The following is a description of a gene set: from publication Chen Y, Wang X (PMID 31504780) Human Gene Set: MIR1193 species: Homo sapiens Genes predicted to be targets of miRBase v22 microRNA hsa-miR-1193 in miRDB v6.0 with MirTarget v4 prediction scores > 80 (high confidence targets)., and this is the list of marker genes: SMG6, HTR4, ARID2, GPLD1, TMEM11, GPM6A, YY1AP1, CMTR2, GSG1L, ITGAV, USP15 (NCBI Gene Id 9958), ORC4, PLEKHB1, SLC1A3, MBD2, TOMM20, ERMAP, TLK2, CHD9, RYR2, CES4A, FAM169BP, PLPPR5, NCK2, SUCLG2 (NCBI Gene Id 8801), TATDN3, NMI, CADM2, IGF2BP2, TM9SF3, LASP1, GNG13, PTK2, MBNL3, TRIM27